Given this list of marker genes METTL2A, POLG2, WFDC21P, PPIAP55, RNU6-450P, MIR21, PECAM1, EFCAB3, RPL23AP74, ENSG00000287664, TBC1D3P2, TBX2 (T-box transcription factor 2), TANC2, GH2, CA4, EEF1DP7, FAM136DP, MIR633, LIMD2, SNHG25, TBC1D3P1-DHX40P1, MIR3064, RPSAP66, RPL36AP46, RNU4-13P, CSH1, TLK2, CSHL1, RNFT1-DT, LINC01476, MARCHF10-DT, CHCT1, TBC1D3P1, PSMC5, BCAS3-AS1, DDX42, TACO1, STRADA, SCARNA20, SCN4A, TCAM1P, CCDC47 (coiled-coil domain containing 47), MAP3K3, RN7SL800P, CEP95, DENRP3, MRC2, USP32P4, PPM1D, GH1, NACA2, PRELID3BP3, ENSG00000293358 (NCBI Gene Id 654127), RNU6-288P, ERN1, RN7SL448P, CSH2, PRR29, DNAJB6P8, BCAS3, RNU6-446P, ENSG00000297717, LINC02875, SMARCD2, RPS23P7, RPL31P57, TBX4, MIR5047, BRIP1, TBX2-AS1, PTRH2, APPBP2-DT, PRR29-AS1, RPL12P38, MARCHF10, RNU7-52P, RNU6-623P, SNORD104, INTS2, KCNH6, POLRMTP1, SNORA50C, TEX2, DHX40P1, NDUFB8P2, SEPTIN7P12, HEATR6-DT, KRT18P61 (NCBI Gene Id 100418865), FTSJ3, RN7SL606P, ICAM2, CLTC, RPS29P21, RNFT1, USP32, ACE, DDX5, MED13, ATP5MFP4, DCAF7, HMGN1P28, RPL32P32, TRMT112P3, CD79B, H3P42, ENSG00000265702, HEATR6, RPL36AP47, MIR4737, VMP1, LINC01999, MILR1, TUBD1, CYB561, ENSG00000267248, ENSG00000274565, ACE3P, DHX40, RPS6KB1, APPBP2 (NCBI Gene Id 10513), here is a description of the gene set: Human Gene Set: chr17q23 studied in species Homo sapiens